Given this list of marker genes PSMD2, PSMC6, PSMB6, PSMC4, PSMD12, UBA52, PSMB2, SEM1, SMURF2, RNF146, PSMA3, RPS27A, TNKS2, TNKS, PSMD14, PSMA4, PSMD6, PSMA5, PSMB5, PSMA2, PSMD8, AXIN1, PSMB7, PSMD3, AXIN2, UBC, PSMB3, PSMD13, PSMC2, PSMD7, PSMC1, PSMC5, PSMB1, PSMC3, PSMA1, ADRM1, UBB, PSMA7, PSMD11, PSMB4, PSMA6, PSMD1, here is a description of the gene set: part of: TCF dependent signaling in response to WNT AXIN is present in low concentrations in the cell and is considered to be the limiting component of the beta-catenin destruction complex in Xenopus; this may not be the case in mammalian cells, however. Cellular levels of AXIN are regulated in part through ubiquitin-mediated turnover. E3 ligases SMURF2 and RNF146 have both been shown to play a role in promoting the degradation of AXIN by the 26S proteasome. Reactome Pathway: Degradation of AXIN species: Homo sapiens